The following is a description of a gene set: Activation of C3 and C5 species: Mus musculus Mouse Gene Set: REACTOME_ACTIVATION_OF_C3_AND_C5, and this is the list of marker genes: C4b, Cfb, C3, Cfp, Hc, C2